Given this list of marker genes Il20ra, Ifnl3, Stat5b, Il20, Tyk2, Il19, Il24, Ifnlr1, Stat4, Stat5a, Ifnl2, Jak3, Il22, here is a description of the gene set: part of: Signaling by Interleukins electronically inferred by orthology from the curated human pathway species: Mus musculus Reactome Pathway: Interleukin-20 family signaling This event has been computationally inferred from an event that has been demonstrated in another species.<p>The inference is based on the homology mapping from PANTHER. Briefly, reactions for which all involved PhysicalEntities (in input, output and catalyst) have a mapped orthologue/paralogue (for complexes at least 75% of components must have a mapping) are inferred to the other species.